Given this list of marker genes PGAP1, TMEM106B, MT-ATP6, CNGB3, LRP5, TRPV6, ITPR1, NUP54, ARHGEF2, KRT14, PAX6, HMX1, GRIK2, ATP6V1B2, ADAR, NUP62, TBC1D24, ROBO1, ZFX, EXOSC9, KRT5, FRMD7, HPS3, here is a description of the gene set: Congenital nystagmus Human Gene Set: HP_CONGENITAL_NYSTAGMUS Nystagmus dating from or present at birth. studied in species Homo sapiens